Given this list of marker genes FMO3, FMO2 (NCBI Gene Id 2327), FMO1, here is a description of the gene set: Reactome Pathway: FMO oxidises nucleophiles Flavin-containing monooxygenases (FMOs) are the second family of microsomal oxidative enzymes with broad and overlapping specificity. The major reactions FMOs catalyze are nucleophilic hetero-atom compounds such as nitrogen, sulfur or phosphorus as the hetero-atom to form N-oxides, S-oxides or P-oxides respectively. Despite the functional overlap with cytochrome P450s, the mechanism of action differs. FMOs bind and activate molecular oxygen before the substrate binds to the enzyme (picture). They also require flavin adenosine dinucleotide (FAD) as a cofactor. Unlike cytochrome P450 enzymes, FMOs are heat-labile, a useful way to distinguish which enzyme system is at work for researchers studying metabolism. Also, FMOs are not inducible by substrates, unlike the P450 enzymes.\n<font color=red>(1)</font> NADPH binds to the enzyme and reduces the prosthetic group FAD to FADH<sub>2</sub>. NADP<sup>+</sup> remains bound to the enzyme.\n<font color=red>(2)</font> Incorporation of molecular oxygen to form a hydroperoxide.\n<font color=red>(3)</font> A peroxide oxygen is transferred to the substrate.\n<font color=red>(4)</font> Water is released.\n<font color=red>(5)</font> NADP<sup>+</sup> dissociates returning the enzyme to its initial state.\n\nTo date, there are 6 isozymes of FMO (FMO1-6) in humans, the most prominent and active one being FMO3. The FMO6 gene does not encode for a functional enzyme although it has the greatest sequence similarity with FMO3 (71%), whilst the others range from 50-58% sequence similarity with FMO3. FMO1-3 are the ones that exhibit activity towards nucleophiles, the others are insignificant in this respect. part of: Phase I - Functionalization of compounds species: Homo sapiens